The following is a description of a gene set: studied in species Mus musculus Mouse Gene Set: HESS_TARGETS_OF_HOXA9_AND_MEIS1_UP Genes up-regulated in hematopoietic precursor cells conditionally expressing HOXA9 and MEIS1. from publication Hess JL, Bittner CB, Zeisig DT, Bach C, Fuchs U, Borkhardt A, Frampton J, Slany RK (PMID 16507773) Abdominal-type HoxA genes in combination with Meis1 are well-documented on-cogenes in various leukemias but it is unclear how they exert their transforming function. Here we used a system of conditional transformation by an inducible mixed lineage leukemia-eleven-nineteen leukemia (MLL-ENL) oncoprotein to overexpress Hoxa9 and Meis1 in primary hematopoietic cells. Arrays identified c-Myb and a c-Myb target (Gstm1) among the genes with the strongest response to Hoxa9/Meis1. c-Myb overexpression was verified by Northern blot and quantitative reverse transcription-polymerase chain reaction (RT-PCR). Also MLL-ENL activated c-Myb through up-regulation of Hoxa9 and Meis1. Consequently, short-term suppression of c-Myb by small inhibitory RNA (siRNA) efficiently inhibited transformation by MLL-ENL but did not impair transformation by transcription factor E2A-hepatic leukemia factor (E2A-HLF). The anti c-Myb siRNA effect was abrogated by coexpression of a c-Myb derivative with a mutated siRNA target site. The introduction of a dominant-negative c-Myb mutant had a similar but weaker effect on MLL-ENL-mediated transformation. Hematopoietic precursors from mice homozygous for a hypo-morphic c-Myb allele were more severely affected and could be transformed neither by MLL-ENL nor by E2A-HLF. Ectopic expression of c-Myb induced a differentiation block but c-Myb alone was not transforming in a replating assay similar to Hoxa9/Meis1. These results suggest that c-Myb is essential but not sufficient for Hoxa9/Meis1 mediated transformation., and this is the list of marker genes: Gstm1, Trp53bp1, Cldn15, Metap2, Ruvbl2, Rhoj, Msh2 (NCBI Gene Id 17685), Hdac2, Pinx1, Hmgcr, Mrpl15, Hoxa9, Uhrf1, Dtymk, Tfap4, Trip13, Immt, Afp, Got1, Asns (asparagine synthetase), Ide, Nedd4 (NCBI Gene Id 639396), Cdc45, Bid, Myb, Dnaja3, Entpd4, Icam2, Schip1, Prmt1, Klf9, Fabp5, Slc26a6 (NCBI Gene Id 171429), Bcl7c, Ppan, Ruvbl1, Ncl, Lin28a, Rrs1, Bet1, Pde7a, Dut, Ybx3 (Y box protein 3), Mcm7, Snrpa1, Mcm3, C1qbp, Trmt2a, Odc1, Ctps1, Cd28, Gas5, Mybl2, Rrm1, Mcm3ap, Mylk, Phgdh, Psmg2, Nop58, Ppid, Muc13, Tst, Bcat1, Gabpb1, Nucb2, Cebpa (CCAAT/enhancer binding protein alpha), Wee1, Nolc1, Ifrd2 (NCBI Gene Id 67007)